Given this list of marker genes HBZ, HBG2, EPX, HDAC6, PRDX1, MGST3, LTC4S, IPCEF1, GPX1, HBA2, PTGES, GPX6, PARK7, PTGS1 (NCBI Gene Id 5742), LRRK2, GPX3, HBD, LPO, PXDN, TPO, GPX8, GSTT1, HBQ1, HBG1, MGST2, SESN3, GPX7, CLIC2 (NCBI Gene Id 1193), DUOX1, PTGS2, HBM, PXDNL, GSTK1, MB, GPX5, GSTA1, GSTM2, DUOX2, ALOX5AP, TXNRD1, GSTP1, CYGB, MGST1, SESN1, MPO, HBB, GSTZ1, GPX4, SELENOF, CP, PRDX6, PRDX5, TXNDC17, PRDX4, GPX2, PRDX3, SESN2 (NCBI Gene Id 83667), HBA1, CAT, PRDX2, HBE1, here is a description of the gene set: Catalysis of an oxidation-reduction (redox) reaction in which the peroxide group acts as a hydrogen or electron acceptor. Human Gene Set: GOMF_OXIDOREDUCTASE_ACTIVITY_ACTING_ON_PEROXIDE_AS_ACCEPTOR studied in species Homo sapiens